The following is a description of a gene set: Abnormal shoulder morphology An abnormality of the shoulder, which is defined as the structures surrounding the shoulder joint where the humerus attaches to the scapula. studied in species Homo sapiens Human Gene Set: HP_ABNORMAL_SHOULDER_MORPHOLOGY, and this is the list of marker genes: B3GAT3, TNNT1, NGLY1 (N-glycanase 1), ARFGEF2, OTUD6B, PTCH1, MEG3, VPS37D, NCF1, PTPN2, HHAT, ATP7A, TBX5, COL1A2, PIEZO2 (piezo type mechanosensitive ion channel component 2), SCARF2, SALL4, CUL4B, FLNA, EYA1 (NCBI Gene Id 2138), BCOR, RTL1, GDF6, BRD4, EFNB1 (NCBI Gene Id 1947), ORC1, ARF1, BUD23, STX1A, SPRTN, RUNX2, HSPG2, LMX1B, MLXIPL, PPP1R15B, EIF4H, DYM, GABRA3, GSC, SCN4A, TRAPPC2, COL12A1, IRX5, MAP1B, AEBP1, CHRNG, GDF3, TBL2, JAG2, CCN6, GTF2I, PRNP, KY, GNB2, COL1A1, COL6A2, STAT4, BAZ1B, RNU4ATAC, FKBP6, FIG4, CBFB, GNPTG, IL2RA, LMNA, LMBRD2, PTPN22, FILIP1, MYL11, NAA10, TRPV4 (transient receptor potential cation channel subfamily V member 4), RBM8A, MEOX1, MYH3, TMEM270, GTF2IRD2, COL5A1, IL2RB, LGI4, DNAJC30, NEDD4L, FGFR2, TMTC3, ANKRD55, LYSET, COL5A2, TRMT10A, CLIP2, ELN, PAX1, ABCC6, CD247, CHD7, GTF2IRD1, ENPP1, DLK1, LIMK1, CHST3, METTL27, RFC2, ERMARD